The following is a description of a gene set: from publication Gho JW, Ip WK, Chan KY, Law PT, Lai PB, Wong N (PMID 18701499) Genes up-regulated in HEP3B cells (liver cancer) overexpressing ATF5 off a plasmid vector. Human Gene Set: GHO_ATF5_TARGETS_UP studied in species Homo sapiens Transcription factors represent an important class of genes that play key roles in controlling cellular proliferation, cell cycle modulation, and attractive targets for cancer therapy. Here, we report on the novel finding of common ATF5 down-regulations in hepatocellular carcinoma (HCC), a highly malignant tumor with a dismal clinical course. Array-based mapping in HCC highlighted a high and consistent incidence of transcription factor ATF5 repressions on regional chr.19q13. By quantitative reverse transcription-PCR, profound down-regulations of ATF5 were further suggested in 78% of HCC tumors (60 of 77 cases) compared to their adjacent nontumoral liver (P = 0.0004). Restoration of ATF5 expression in 3 nonexpressing HCC cell lines demonstrated a consistent growth inhibitory effect (P < 0.029) but minimal induction on cellular apoptosis. Subsequent flow cytometric investigations revealed a G(2)-M cell cycle arrest in HCC cells that were ectopically transfected with ATF5 (P < 0.002). The differential expressed genes from the functional effects of ATF5 were examined by array profiling. Over a hundred genes were identified, among which ID1 contains the ATF/CREB target binding sequences within its promoter region. An inverse relationship between ATF5 expressions with ID1 transcriptions was verified in HCC (P = 0.019), and a direct interaction of ATF5 on the promoter of ID1 was further demonstrated from electromobility shift assay. Examination of causal events underlying the silencing of ATF5 in HCC suggested copy number losses, promoter hypermethylation, histone deacetylation, and DNA mutations to be the likely inactivating mechanisms. In conclusion, our finding supports a tumor suppressive role for ATF5 in HCC, and highlighted ID1 as a potential downstream target., and this is the list of marker genes: GPT2, ZNF658, NEB, ATP11B, ITIH3, LAMB2, RIF1, IFT88 (intraflagellar transport 88), RBM45, EIF4G2, NOP58, TAB2, RHOBTB1